Given this list of marker genes HNMT, SLC29A4, HDC, PRG3, TRH, SLC22A3, here is a description of the gene set: species: Homo sapiens Human Gene Set: GOBP_HISTAMINE_METABOLIC_PROCESS The chemical reactions and pathways involving histamine, a physiologically active amine, found in plant and animal tissue and released from mast cells as part of an allergic reaction in humans.